The following is a description of a gene set: Early tip Human Gene Set: HE_LIM_SUN_FETAL_LUNG_C1_EARLY_TIP_CELL studied in species Homo sapiens from publication He P, Lim K, Sun D, Pett JP, Jeng Q, Polanski K, Dong Z, Bolt L, Richardson L, Mamanova L, Dabrowska M, Wilbrey-Clark A, Madissoon E, Tuong ZK, Dann E, Suo C, Goh I, Yoshida M, Nikolić MZ, Janes SM, He X, Barker RA, Teichmann SA, Marioni JC, Meyer KB, Rawlins EL (PMID 36493756), and this is the list of marker genes: PIMREG, CIP2A, MCM6, KIF20A, RAD54L, CENPM, CBS (cystathionine beta-synthase), AURKB, LAMA1, HSPA6, PBK, H3C2, NUSAP1, LINC00511, CDC6, CENPN, PLK1, H2BC9, MASTL (NCBI Gene Id 84930), CEACAM21, CHAF1A (chromatin assembly factor 1 subunit A), STRA6, WASF1, PMAIP1, TACC3, DSCC1 (DNA replication and sister chromatid cohesion 1), CTNND2, UBE2C, CDC20, FANCD2, H1-1 (NCBI Gene Id 3024), UQCRHL, RNF175, SPC24, CENPF, NUF2, SYT11, SCD, HSPB8, GPC2, TK1, FANCA, LOXL3, H3C15, APOC1, TTR, ST8SIA2, RND2, FGF13, PCDH17, MYBL2, GALNT6, ALPL, PARD6G-AS1, CNFN, DNA2, FBXO5, CHEK1, CDCA5, DLGAP5, APOA1, VCAN, CHST6, TSPAN2, PSMC3IP, CDCA3, NES, CDK1, NUDT11, CENPU, MELK, POC1A, ACOT7, GUCY1A2 (guanylate cyclase 1 soluble subunit alpha 2), COL9A1, TMEFF1 (NCBI Gene Id 8577), HNRNPA1L3, SHISAL2B, CCNA2, TPX2, PGP, IHH, KIF14, CLSPN, CDC45, SPC25, BEX1, CENPE, DEPDC1B, CDCA8, CCNB2, CTPS1, CENPH, GYPC, GINS4, TRIP13, HDC, SLC12A5, SGO1 (NCBI Gene Id 151648), TUBB3, TTYH1, MCM4, TRAIP, MPZ, TOP2A, ARG2, MAD2L1, E2F1, LINGO1, MND1, ACVR1B, TPM2, FADS2, FOXM1, GTSE1, UHRF1 (ubiquitin like with PHD and ring finger domains 1), C6orf141, TCEAL7, PKN3, NCAPH, SNAI1, ORC6 (NCBI Gene Id 23594), CTXN1, SERPINE2, RFX6, COL26A1, HAGLROS, BIRC5, H2AC13, UBE2T, ZWINT, C5orf34, FIRRM, CENPW, CPXM1, GADD45G, GLDC, LINC01315, FAM83D, LINC01224, HSPA2, MCM10, KCNN1, GAS2, PRKCA